The following is a description of a gene set: human blood monocytes were isolated, activated and harvested at several timepoints In this study, we identified genes that were differentially expressed in human monocytes activated with eiter NOD2L and/or TLR2/1L. studied in species Homo sapiens from publication Schenk M, Krutzik SR, Sieling PA, Lee DJ, Teles RM, Ochoa MT, Komisopoulou E, Sarno EN, Rea TH, Graeber TG, Kim S, Cheng G, Modlin RL (PMID 22447076) Human Gene Set: GSE34156_UNTREATED_VS_24H_NOD2_AND_TLR1_TLR2_LIGAND_TREATED_MONOCYTE_DN Genes down-regulated in monocytes (24h): untreated versus muramyl dipeptide andM. tuberculosis 19 kDa lipopeptide., and this is the list of marker genes: FAM83G, LINC00957, C19orf84, LINC00308, RMI2, YBX2, NDUFS8, ADAT3, AMDHD1, LAMB2, TMEM59L, LRRC15, RBM38, PIGZ (NCBI Gene Id 80235), PRB4, ZNF839, EDN2, PRRG3, OSBPL5, TPH1, TLL2, GAS6, RHBDL1, YY2, WDR31, SPACA4, LINC03122, INTS9, PHF21B, ZGLP1, SLC13A3, TSEN34, H1-8, SLC23A1, RASAL3, CYP2D6, NISCH, ZNF787, DRD2, GAK, GAS8-AS1, TMEM17, ITGA11, CTBP1-DT, ILVBL, RADIL, TPO, C15orf61, MGAT5B (NCBI Gene Id 283995), NOX1, GARIN3, IQCH, LRRC14, MED16, GABBR2, CDH16, RNF212, INF2, FGF14-AS2, ITIH1, TRPC4, NIPSNAP3B, FBF1 (NCBI Gene Id 85302), SLC9A3-AS1, LINC00628 (NCBI Gene Id 127841), PIK3R2, PM20D2, DPH3P1, B4GALT2, FAM50B, TBXA2R, SCUBE1, C1QL1, VWCE, CHERP, CYRIA, EPHX3, CXCL14, SCO2, SHD, FAM200C, ARMH1, ISLR, CES3, HRCT1, ACAD10, CASP5, LINC00705, MICAL3, LCN12, NOBOX, POPDC3, BCO2, CCDC13, FOXP2, DNAI7, BRSK2, MLF1, SLX4, LCE1E (NCBI Gene Id 353135), SNORA17B, SSBP4, MIOS, SLC28A3, OCM2, HOXA11, PSORS1C1, ZFP41, DPF1, NTN5, CFC1, WSCD2, VCX2, HTR1B, CLEC16A, EPB42, ZNF710, KIF25-AS1, MVD, H3-4, APELA, C1QTNF2, CREB3L4, TRPV5 (NCBI Gene Id 56302), STEAP1B, KCNJ5, LRRC52-AS1, LHX4, NUTM2F (NUT family member 2F), DEFB119, GOLT1A, SMG1P2, WNT9A, C20orf181, REEP2, AKR7A2, SCG2, COPS4, CCDC8, ADAM20, DCHS1, MIA, TSSK3 (NCBI Gene Id 81629), PLCD3, TSPAN6, CDH4, PTPA, KLF5, PTGR1, AKR1B10, B3GNT9, RAB36, ZPBP, CCDC22, LINC01342, NMRK2, SCN1B, TNNC2, PPIC, MC1R, TAC1, AGPAT3, MAP1S, FPR1, RAI1, PCDHGB8P, TLDC2, HACD1, KIF2C, TBX20, ZNF707, ARVCF, RELL2, LINC00491, TRAM2-AS1, PNLIPRP2, LINC01120, NME3, FSIP1, USP2, PIP4K2B